Given this list of marker genes ADAP2, PAMR1 (NCBI Gene Id 25891), MMP9, WDR77, ISG15, HOPX, RPS11, MUC1, MXRA5, TWIST1, STC1, CHN1, FOXF2, TNFRSF21, PMAIP1, EGFL6, FJX1, ADAM12, COL5A3, SCIN, HSPA6, VCAN (versican), POSTN, FZD10, LCP2, PLXDC1, TNFAIP6, CMTM8, SPP1, here is a description of the gene set: Therapeutic strategies based on antiangiogenic approaches are beginning to show great promise in clinical studies. However, full realization of these approaches requires identification of key differences in gene expression between endothelial cells from tumors versus their normal counterparts. Here, we examined gene expression differences in purified endothelial cells from 10 invasive epithelial ovarian cancers and 5 normal ovaries using Affymetrix U133 Plus 2.0 microarrays. More than 400 differentially expressed genes were identified in tumor-associated endothelial cells. We selected and validated genes that were overexpressed by 3.6- to 168-fold using real-time reverse transcription-PCR and/or immunohistochemistry. Among these, the polycomb group protein enhancer of Zeste homologue 2 (EZH2), the Notch ligand Jagged1, and PTK2 were elevated 3- to 4.3-fold in tumor-associated endothelial cells. Silencing these genes individually with small interfering RNA blocked endothelial cell migration and tube formation in vitro. The present study shows that tumor and normal endothelium differ at the molecular level, which may have significant implications for the development of antiangiogenic therapies. studied in species Homo sapiens Human Gene Set: LU_TUMOR_VASCULATURE_UP from publication Lu C, Bonome T, Li Y, Kamat AA, Han LY, Schmandt R, Coleman RL, Gershenson DM, Jaffe RB, Birrer MJ, Sood AK (PMID 17308118) Genes up-regulated in endothelial cells derived from invasive ovarian cancer tissue.